Given this list of marker genes STAT5B, LDB1, KLF13, HSPA9, YPEL4, HOXA5, ZFP36L1, ZFP36, MAFB, STAT5A, here is a description of the gene set: studied in species Homo sapiens Any process that stops, prevents, or reduces the frequency, rate or extent of erythrocyte differentiation. Human Gene Set: GOBP_NEGATIVE_REGULATION_OF_ERYTHROCYTE_DIFFERENTIATION